Given this list of marker genes RWDD3, SENP1, SENP5, SAE1, UBE2I, SUMO2, UBA2, SENP2, SUMO1, SUMO3 (NCBI Gene Id 6612), here is a description of the gene set: species: Homo sapiens Human Gene Set: REACTOME_PROCESSING_AND_ACTIVATION_OF_SUMO Processing and activation of SUMO